Given this list of marker genes SHLD3, BRD8, SMARCD1, SMCHD1, RNF126, NBN, ING3, PELI1, SPIRE1, DMAP1, CREBBP, HELQ, KMT5C, ARID1B, MAD2L2, PNKP, MORF4L1, WDR48, SMARCB1, MRE11, FH, ZCWPW1, RAD50, MORF4L2, CYREN, PRKDC, RUVBL1, MEAF6, BCL7C, SHLD2, UBE2V2, DDX11, SMARCD3, MRNIP (MRN complex interacting protein), MBTD1, ACTR2, PBRM1, RNF8, KMT5B, RUVBL2, FMN2, RIF1, SMARCA2, FUS, SLF2, ACTL6B, EPC1, SIRT1, KDM4D, DPF2, BCL7A, PIAS4, ATM, SMARCC1, ARID2, AGER, SMARCC2, SPIRE2, ACTB, ERCC6, SHLD1, SMARCE1, VPS72, MRGBP, MGMT, SMARCD2, TOP2B, SIRT6, PHF10, KAT5 (NCBI Gene Id 10524), EP400 (NCBI Gene Id 84442), DPF3, YEATS4, OOEP, PRMT1, ACTL6A, EPC2, DPF1, UBE2N, WRAP53, HDGFL2, SPIDR, PARP3, BRD7, RAD51AP1, ARID1A, SETMAR, SKP2, BCL7B, FOXM1, KHDC3L, TRRAP, PARP1, TIMELESS, SLF1, WAS, FANCB, SMARCA4, here is a description of the gene set: Any process that activates or increases the frequency, rate or extent of double-strand break repair. Human Gene Set: GOBP_POSITIVE_REGULATION_OF_DOUBLE_STRAND_BREAK_REPAIR species: Homo sapiens